Given this list of marker genes TMEM50A, DNAI2, CFAP221 (cilia and flagella associated protein 221), HEPACAM, ADCY10, FYN, ABCA7 (NCBI Gene Id 82843), GRM3 (NCBI Gene Id 2913), AIF1, GFAP, CLCN2, GLUL, GRM2, ATP1B2, CROCC, ADGRG1, APP, ITGB1, SIRT2, DNAH9 (dynein axonemal heavy chain 9), MLC1, SYT4, PINK1, SLC2A13, SLC7A11, SLC17A8, SLC1A2, CNTF, SCN7A, FMR1, GRM5, SLC1A1 (solute carrier family 1 member 1), WASF3, KCNK2, ERMN, CNGA3, PACRG, KCNJ10, DNAH5, SLC4A8, CETN2, MAPT, EIF2S1, DNAI1, CRB1, LCP1, MT3, AQP4, here is a description of the gene set: species: Homo sapiens A prolongation or process extending from a glial cell. Human Gene Set: GOCC_GLIAL_CELL_PROJECTION